The following is a description of a gene set: species: Homo sapiens Human Gene Set: GOMF_MONOATOMIC_CATION_BICARBONATE_SYMPORTER_ACTIVITY Enables the transfer of a solute or solutes from one side of a membrane to the other according to the reaction: monoatomic cation(out) + HCO3-(out) = monoatomic cation(in) + HCO3-(in)., and this is the list of marker genes: SLC4A8, SLC39A4, SLC4A9, SLC39A12, SLC39A5, SLC4A7, SLC39A10, SLC39A8, SLC4A5, SLC39A6, SLC4A4, SLC4A10, SLC39A14